The following is a description of a gene set: Human Gene Set: GOBP_POSITIVE_REGULATION_OF_D_GLUCOSE_TRANSMEMBRANE_TRANSPORT Any process that increases the frequency, rate or extent of glucose transport across a membrane. Glucose transport is the directed movement of the hexose monosaccharide glucose into, out of or within a cell, or between cells, by means of some agent such as a transporter or pore. studied in species Homo sapiens, and this is the list of marker genes: OSBPL8, ITLN1, FGF21, APPL1, OCLN, NFE2L2, MEF2A, GH1, AKT2, OPN3, CLTCL1, PTH, ARPP19 (NCBI Gene Id 10776), KLF15, SLC1A2, ERFE, SORBS1, IRS2, POU4F2, C2CD5, RHOQ, INSR, CAPN10, FGF19, PTPN11, CLIP3, RNASEL, BRAF, CREBL2, NR4A3, ADIPOQ, MIR223, PRKCI, IGF1, C1QTNF12, INS, GPC3 (NCBI Gene Id 6394), PIK3R1, C3, IRS1, MAPK14, RAP1A, PTPRM, AKT1, TERT, ZDHHC7